The following is a description of a gene set: electronically inferred by orthology from the curated human pathway part of: Cytochrome P450 - arranged by substrate type Reactome Pathway: Vitamins species: Mus musculus This event has been computationally inferred from an event that has been demonstrated in another species.<p>The inference is based on the homology mapping from PANTHER. Briefly, reactions for which all involved PhysicalEntities (in input, output and catalyst) have a mapped orthologue/paralogue (for complexes at least 75% of components must have a mapping) are inferred to the other species., and this is the list of marker genes: Cyp26a1, Cyp24a1 (cytochrome P450, family 24, subfamily a, polypeptide 1), Cyp26b1